The following is a description of a gene set: Oral ulcer species: Homo sapiens Human Gene Set: HP_ORAL_ULCER Erosion of the mucous mebrane of the mouth with local excavation of the surface, resulting from the sloughing of inflammatory necrotic tissue., and this is the list of marker genes: GFI1, BANK1, RIPK1, MAP2K1, DCLRE1C, DNAJC21, SPP1, SRP19 (signal recognition particle 19), UBE2L3, PDCD1, CD40LG, IL10RA, FCGR2B, CR2, PTPN22, KLRC4, TCIRG1, STAT4 (signal transducer and activator of transcription 4), BRAF, MECP2, IFNGR1, G6PC3, SLC37A4, IL12A, ADA2, IL23R, ITGAM, EFL1, CCR1, DOCK11, SBDS, JAZF1, CTLA4, IRAK1, CD27, TNIP1, HLA-DRB1, SYK, TNFSF4, SLC46A1, NRAS, TREX1, MEFV, CAT, TLR4, ETS1, PXK, ELF4, NOD2, CLPB, C4A, C1QB, DNASE1, IL12A-AS1, HLA-B, IGHG1, UBAC2 (UBA domain containing 2), TLR7, IL7R, ERAP1, C4B, ELANE, LYN, SAT1, RELA, BLK, FCGR3B, KIAA0319L, IL10, MVK, IRF5, CYBC1, TNFAIP3, FAS